Given this list of marker genes Sod2, Efemp2, Eng, Cth, Kit, Gper1, here is a description of the gene set: Mouse Gene Set: GOBP_POSITIVE_REGULATION_OF_VASCULAR_ASSOCIATED_SMOOTH_MUSCLE_CELL_DIFFERENTIATION species: Mus musculus Any process that activates or increases the frequency, rate or extent of vascular smooth muscle cell differentiation.